The following is a description of a gene set: Mouse Gene Set: GOBP_REGULATION_OF_GERM_CELL_PROLIFERATION Any process that modulates the frequency, rate or extent of germ cell proliferation. studied in species Mus musculus, and this is the list of marker genes: Fanca, Cib1, Ptgdr2, Prdx4 (peroxiredoxin 4), Ptgds, Src, Hpgds, Il18, Rhbdd1, Rspo1